The following is a description of a gene set: Reactome Pathway: Regulation of localization of FOXO transcription factors Localization of FOXO transcription factors FOXO1, FOXO3 and FOXO4 is regulated by AKT-mediated phosphorylation. In the absence of PI3K/AKT signaling, FOXO1, FOXO3 and FOXO4 localize to the nucleus. AKT-mediated phosphorylation induces a conformational change that exposes a nuclear export signal (NES) and promotes translocation of FOXO1, FOXO3 and FOXO4 to the cytosol. AKT-phosphorylated FOXO1, FOXO3 and FOXO4 bind to 14-3-3 proteins, which contributes to their retention in the cytosol. FOXO6 lacks the NES sequence and is exclusively nuclear, but phosphorylation in response to PI3K/AKT signaling affects the transcriptional activity of FOXO6. part of: FOXO-mediated transcription species: Homo sapiens, and this is the list of marker genes: YWHAZ, AKT1, SFN, FOXO4, AKT3, FOXO1, YWHAB, AKT2, YWHAG, FOXO3, YWHAQ, FOXO6